The following is a description of a gene set: species: Homo sapiens Neighborhood of EGFR epidermal growth factor receptor (erythroblastic leukemia viral (v-erb-b) oncogene homolog, avian) in the GNF2 expression compendium Human Gene Set: GNF2_EGFR Neighborhood of EGFR, and this is the list of marker genes: PAGE4, PSG1, PSG9, SVEP1, PSG6 (pregnancy specific beta-1-glycoprotein 6), FBN2, PLAC1, GDF15, KISS1, TFAP2A, SDC1, PSG3, GCM1, HSD3B1, LGALS14, CAPN6, EGFR, TIMP2, PSG5, HSD17B1, ADAM12, PSG2, PAPPA2, ALPP, SERPINB2, CYP19A1, PSG4, PAPPA, PSG7, MAFF, GH2, CRH